The following is a description of a gene set: Regulation of cytoplasmic and nuclear SMAD2/3 signaling from publication Schaefer CF, Anthony K, Krupa S, Buchoff J, Day M, Hannay T, Buetow KH (PMID 18832364) studied in species Homo sapiens Human Gene Set: PID_SMAD2_3PATHWAY, and this is the list of marker genes: MAPK1, SMAD3, MAP3K1, PPM1A, KPNB1, NUP153, MAPK3, UBE2I, CTDSP1, CTDSPL, SMAD2, NUP214, CTDSP2, SMAD4, PIAS4, KPNA2 (karyopherin subunit alpha 2)